The following is a description of a gene set: Human Gene Set: GOBP_T_CELL_ACTIVATION The change in morphology and behavior of a mature or immature T cell resulting from exposure to a mitogen, cytokine, chemokine, cellular ligand, or an antigen for which it is specific. species: Homo sapiens, and this is the list of marker genes: IL21, SP3, CGAS, ACTB, RABL3, CCR2, SLA2, SLAMF9, SOD1, HLA-DQB2, SIRPA, PDCD1LG2, ABL1, IFNG, HLA-DMB, CLPTM1 (CLPTM1 regulator of GABA type A receptor forward trafficking), LFNG, NRARP, MEN1, TCIRG1, IL15 (NCBI Gene Id 3600), FLOT2, LILRB2, LCK, BAG6, SRF, ZMIZ1, ARID1B, PRNP, SYK, SOCS3, CD3D, TP53, TIGIT, CD55, IFNA21, IGFBP2, HLA-G (major histocompatibility complex, class I, G), TNFSF9, PAWR, BCL2, HLA-DRB4, PREX1, CEACAM21, PIK3CG, CCL19, LEP, CD151, PHF10, MYH9, GPR18, VTCN1, CD28, SIRPG (NCBI Gene Id 55423), STK11, FGL2, SDC4, FUT7, IL2RA, HLA-DOB, JMJD6, BCL11B, ZNF683, HLX, NCK2, FOXP3, BRD2, P2RX7, FOXJ1, NLRP3, FYN, EFNB2, ITPRIPL1, FBXO38, ACTL6B, ITPKB, RASAL3, ARID1A, PPP3CA, LGALS9C, TSC1, STAT5A, PIK3R6, CD40LG, FANCA, VAV1, TMEM131L, SMARCA2, NKAP, IL7R, SMAD3, CD84, IFNA8, FCHO1, ZFP36L1, KIF13B, UFL1, GPR65, SIRPB1, SEMA4A, IL6R, SLAMF7, ZBTB1, TRAF2, TRBC2, SMARCD3, SMARCB1, ZBTB16, SPI1, SCRIB, CD27, DLG5, ICOSLG, LOXL3, TCF7, CTNNB1, TNFSF4, CD274, FCER1G, MALT1, MSN, ITCH, CTLA4, CD86, SOCS1, PLA2G2D, PPP3CB, MAFB, IFNA7, CD74, MICB, CBLB, MAD1L1, CARD11, RHOH, PRKAA1, PTPN2, ATP7A, PATZ1, PBRM1, SART1, BRD4, BID, IFNW1, TWSG1, IL4R, ADORA2A, LCP1, AGER, LGALS8, CLC, SOX12, CD46, INS, NCKAP1L, BATF, CD276, TSPAN32, CTSL, SOS1, CRACR2A, CD80, CD24, RUNX1, IFNA1, CSK, BTN3A1, LY9, MTOR, TNFRSF1B, IFNK, SPN, IGF1, SMARCA4, DHPS, PLA2G2F, IFNA17, TMEM98, HHLA2, PRDX2, TGFBR2, LAX1, TREML2 (NCBI Gene Id 79865), RORC, RSAD2, CHD7, RIPK2, PRKCQ, LIG4, HLA-DQA1 (NCBI Gene Id 7946), PIK3R3, IL36B, CORO1A, DAPL1, CADM1, TNFSF14, FKBP1A, TFRC, IFNA4, CLEC7A, STAT3 (signal transducer and activator of transcription 3), EGR1, HLA-DQA2, PCK1, PTPN22, SLC7A1 (solute carrier family 7 member 1), NR5A2, FOXN1, XBP1, HSH2D, HFE, CEBPB, NFATC3, PTCRA, B2M, METTL3, SLAMF1, IL4I1, BTN2A2, EPO, TNFSF8 (TNF superfamily member 8), IL12RB1 (interleukin 12 receptor subunit beta 1), FGL1, IFNA6, TOX, LYN, PAG1, PDPK1, CD81, ICOS, CTSG, CLEC4D, AIRE, KLHL22, CD209, LGALS3, CCL5, RAG2, FKBP1B, IL1B, GPAM, TRAF6, CRTAM, IL10, WNT1, CLEC4G, SOCS5, SOCS6, TRAF3IP2, SOX4, FOSL2, HLA-DMA, AP3D1, PLXNA1, AP3B1, LGALS9, CCL21, CUL4A (cullin 4A), JAG2, CCR7, ATG5, IL23A, GLI2, F2RL1, KMT2A, RIPK3, CCR6, SMARCC2, HLA-A, IFNA14, MYC (MYC proto-oncogene, bHLH transcription factor), STAT6, IHH, JAK1, WAS, IL1RL2 (NCBI Gene Id 8808), CASP3 (caspase 3), CCDC88B, IFNA5, DUSP3, PTPN6, DTX1, JAK2, PIK3CD, SLC46A2, TESPA1, DLG1, HSPH1, RPS3, RUNX2, CD5, MIR21, PRELID1, ACTL6A, BMI1, CYP26B1, AZI2, DLL4, TGFB1, GATA3, IL20RB, DROSHA, CDKN2A, SMARCC1, KAT7, RORA (NCBI Gene Id 6095), PYCARD, HLA-DPB1 (major histocompatibility complex, class II, DP beta 1), IL2, MAP3K8, CD1D, PIK3R1, ERBB2, TNFSF13B, AMBRA1, RASGRP1, ILDR2, ITK, PSMB11, MIR181C, OPA1, IFNB1, YWHAG, BRD7, ADAM8, SCGB1A1, FOXO3, LGALS9B, CLEC4A, KAT2A, TBK1, IKZF3, DUSP10, GLMN, CD1C, NLRC3, IL2RG, SMARCD1, LILRB4, IL6, ARID2, RPL22, HLA-DRB3, TARM1, CD3E, PSEN1 (NCBI Gene Id 5663), NKG7, LGALS1, CEACAM1, GBA1, MR1, RAB29, NOD2, PRKCZ, NCR3, CD300A, ADAM17, IL1A, CD70, PIK3R2, ARG2, CDK6, CD4, WNT10B, CYRIB, BTLA, MDK, ADA, SH3RF1, LRRC32, IFNA2, PSG9, PKNOX1, FZD8, LMO1, RBX1, ARMC5, CD47, PRKAR1A, IL6ST, PLA2G2A, RC3H2, ZNHIT1, ENTPD7, KLRC1, CD247, DDOST, TNFRSF13C, BTNL2, EFNB1, VSIR, CYLD, GNRH1, FADD, TRGC1, PRR7, SEMA6D, TNFSF11, CD7, ABL2, TYK2, NCAPH2, NFKBID, RIPOR2, SPINK5, IRF1, DNAJA3, BRAF, RAB27A, LIPA, RC3H1, IFNE, TMIGD2, EBI3, RHOA, ARG1, YES1, KIT (NCBI Gene Id 5086), CR1, STOML2, IL18, HLA-DRA, SLAMF6, MIR27A, RUNX3, XCL1, IGF2, BMP4 (bone morphogenetic protein 4), JAK3, STAT5B, FZD7, TNFAIP8L2 (TNF alpha induced protein 8 like 2), BAX, JUNB, LAPTM5, TBX21, RELB, CD160, FANCD2, PLA2G5, PSMB10, NKX2-3, CD3G, EIF2AK4, IL23R, IL4, KLRK1, CD6 (NCBI Gene Id 923), VSIG4, TNFRSF4, NCSTN, KITLG, HLA-DQB1, TNFSF18, IL27, CD44, KAT5, TRAC, APBB1IP, PTGER4, HLA-E, ANXA1, ZFP36L2, ELF4, LEPR, AKT1, MYB, ZC3H12A, IL18R1, TNFRSF14, KCNK18, CASP8, HAVCR2, ZEB1, PNP, HLA-DRB5, VNN1, IRF4, SMARCE1, DOCK2, BAD, PRKDC, LAG3, NCK1 (NCK adaptor protein 1), IDO1, HSPD1, ASCL2, ZBTB7B, SMAD7, ZP4, BCL3, PTPN11, VCAM1 (vascular cell adhesion molecule 1), RAG1, HLA-DOA, ZP3, SLC11A1, EFNB3, IFNA16, ZAP70, CD69, CBFB (NCBI Gene Id 9163), CD37, CD8A, LMBR1L, LEF1, CD2, AIF1, BCL6, SOS2, LAT, NCR3LG1, SH2D2A, SIT1, DCAF12, TNFRSF21, CDH26, ICAM1 (NCBI Gene Id 3383), CLECL1P, BCL10, WNT4, IL7, SHB, CCND3, CAV1, IFNA10 (NCBI Gene Id 3446), WDFY4, CD8B, CCR9, EGR3, CLEC4E, KDELR1, MAPK8IP1, THY1, SASH3, FOXP1, GPR89B (NCBI Gene Id 728932), KLRC4-KLRK1, SRC, IFNL1, CD83, GPR89A, CCL2, HMGB1, TRDC (T cell receptor delta constant), USP44, LILRB1, FZD5, CXADR, CAMK4, ATF2, DPP4, EOMES, TYROBP, TREX1, GPR183, NDFIP1, SFTPD, TRBC1, GPNMB, RARA, MIR30B, PDCD1, GRB2, TREM2, SLC4A2, STAT4, SPTA1 (spectrin alpha, erythrocytic 1), PDP2, EP300, CTPS1, HLA-DRB1, JAML, KLHL25, GLI3 (GLI family zinc finger 3), SMARCD2, PRDM1 (NCBI Gene Id 639), NHEJ1, ZC3H8, CLEC2B, PTPRC, RAC2, FCGR2B (Fc gamma receptor IIb), PELI1, IL12A, DUSP22, SOX13, MICA, ALKBH5, ZFPM1, THEMIS, NEDD4, TNFRSF9, DOCK8, KLRF1, SELENOK, IL12B, NFKBIZ, GSN, ITGAL, HLA-DPA1, SHH, HES1, MARCHF7